The following is a description of a gene set: Individuals with 22q11.2 microdeletions show behavioral and cognitive deficits and are at high risk of developing schizophrenia. We analyzed an engineered mouse strain carrying a chromosomal deficiency spanning a segment syntenic to the human 22q11.2 locus. We uncovered a previously unknown alteration in the biogenesis of microRNAs (miRNAs) and identified a subset of brain miRNAs affected by the microdeletion. We provide evidence that the abnormal miRNA biogenesis emerges because of haploinsufficiency of the Dgcr8 gene, which encodes an RNA-binding moiety of the 'microprocessor' complex and contributes to the behavioral and neuronal deficits associated with the 22q11.2 microdeletion. Human Gene Set: STARK_PREFRONTAL_CORTEX_22Q11_DELETION_UP studied in species Mus musculus from publication Stark KL, Xu B, Bagchi A, Lai WS, Liu H, Hsu R, Wan X, Pavlidis P, Mills AA, Karayiorgou M, Gogos JA (PMID 18469815) Genes up-regulated in prefrontal cortex (PFC) of mice carrying a hemizygotic microdeletion in the 22q11.2 region., and this is the list of marker genes: ACVR1C, NCDN, MIR9-3HG, GNA13, ATP2B1, MAP3K2, SRSF11, ACTN1, TCF4, TNRC18, ARK2C, MINK1, CAMK2A, RIMBP2, NFIX, LIN7A, GSK3B, KLHL24, SLC6A1, SMARCA2, FOXP1 (NCBI Gene Id 87246), DAB2IP (NCBI Gene Id 84635), SPOCK2, TIMP2, TMEM178B, MIR22HG, PYGM, SP4, SMARCC2, CDC40, SP3, CPNE6, AJM1, PLPPR5, TRAK1, UBR2, SMG7, SHOC2, PRKCG, CYGB, PBX1, TTC7B, NCS1, RHOU, AUTS2, NFIC, CD99L2, MAPRE2, MEF2C, GNAI1, TRIM2, DNAJC27, FBXO41, EMC10, GRK3, DNM2, LINGO1, MALAT1, MIRLET7A3, MTDH, TNFRSF19, STK4, B3GAT1, MYH9, GPRIN1, RBM25, ZC3H11A, NECTIN1, DOT1L, SPRED1 (sprouty related EVH1 domain containing 1), BSN, BIN1, FJX1, NRXN3, MIR29B2, EIF3C, SMARCA5, GPRIN3, PCDH19, CEP70, OR51E2, PRRC2B, NTM, CREG2, AOPEP (aminopeptidase O (putative)), CHD4, USP7, SNX18, OPCML, NACC2, ROCK1, SAFB2, SPTBN1, PTPRJ, PPP2R2C, MIR138-2, SLC1A3, KIF5C, ZNF445, SLC4A4, DLG4, PPP1R1B, EGLN1 (egl-9 family hypoxia inducible factor 1), NUMBL, SRC, DGKD, DLGAP2, PTK2B, SPACA6, MIR377, LPIN2, LENG8, EPS15, IGF1R, FTX, ANKRD11, LPGAT1, CNNM1, PLXNC1, TCAF1, SKI, FNDC3A, BLTP2, R3HDM1, BRD1, SETD7, ZNF804A, TEF, AFTPH, PFKP, SEMA6B, TTYH3, SRRM1, EHD3, KIAA0513, MIR9-2HG, TNPO2, CPEB2, FAR1, TIAL1 (NCBI Gene Id 8430), SOBP, RICTOR, SLC25A23, CHD9, SYN2, ATP8A1, WNK1, PIK3R1, ATN1 (NCBI Gene Id 1822), UBQLN2, CBLL1, EID1, PGM2L1, MEG3, SAMD12, CSNK1A1, ILDR2, ENDOD1, TTC14, ASAP1, POM121, CDK5R1, UBTF, PAQR8, RPL22, CCNI, PTPRK, SLC17A7, ATP1A3, MACROH2A1, ZEB2, CNR1, RSF1, SLC1A2, CPLX2, ARGLU1, LRRC7, KLF9, BPNT2, MARCKS, MEGF9 (multiple EGF like domains 9), CHKA, PPP2R5E, NPTXR, DDX46, OLFM1, ACIN1, SNTB2, NR2C2, GRIA1, OGT, CYFIP2 (cytoplasmic FMR1 interacting protein 2), SLC8A1, CLEC16A, TRIM8, CYRIA, MIA3 (MIA SH3 domain ER export factor 3), MYCBP2, PRKAB2, LSM11, ZBTB16, TMOD2, RALGAPA1, RBM39